Given this list of marker genes RHOJ (ras homolog family member J), S100B, TAOK2, TBCCD1, ARHGAP15, MYH14, PEAK3, MYH10, HCK, PARVA, PALMD, CFDP1, GNA12, SPTA1, EPB41L3, DLG1, RHOBTB2, PLXNC1, CDC42EP5, BVES, C15orf62, SEMA3E, SHROOM3 (NCBI Gene Id 57619), STRIP2, SH3KBP1, CORO1A, PRAG1, ZMPSTE24 (NCBI Gene Id 10269), VEGFA, GNA13, GAS2, HPN, RHOU, PDPN, FMNL1, PALM3, TPM1, RAC1, FBLIM1, LST1, RHOQ, EPS8 (EGFR pathway substrate 8, signaling adaptor), ATP10A, CSF1R, FGR, ARHGAP35, BRWD3, ANXA1, CFL1, SEMA4D, PARVB, CDC42SE2, MSN (NCBI Gene Id 4478), CCL7, MIR21, RAC3, CDC42EP3, FGD4, MYH9, DMTN, ITGA7, CCL24, SEMA4A, RHOG, ITGB2, HEXB, FGD6 (FYVE, RhoGEF and PH domain containing 6), ERMN, FERMT2, DAPK3, ARHGAP18, ARAP1, PHIP, CDC42EP4, MYL12B, ALDOA, SLC26A5, SYNE3, FGD5, CCL13, VIL1, CFAP410, KIT, PLXNB1, YPEL4, DIAPH1, CDC42SE1, PARVG, CCL2, SEPTIN7, FYN, NF2, LIMD1, PLXND1 (plexin D1), RHOBTB1, FN1, WDR1, CDC42EP2 (NCBI Gene Id 10435), DNMBP, PLXNB3, LPAR1, F2, MYO10, FGD2, FGD3, FGD1, RAC2, EPB42, PLEKHO1, CCL3, BRWD1, PALM2AKAP2, RASA1, RDX, KDR, CYFIP1, EZR, CDC42EP1, FMNL3, PTK2, FMNL2, FAM171A1, PALM, FES, MARK2, P2RY1, PRPF40A, MKLN1, BAIAP2, ARHGEF18, F11R, PLXNB2, WASF3, WDPCP, CCL11, PTK2B, COCH, NHERF1, CRK, BAMBI, here is a description of the gene set: species: Homo sapiens Any process that modulates the surface configuration of a cell. Human Gene Set: GOBP_REGULATION_OF_CELL_SHAPE